The following is a description of a gene set: Reactome Pathway: MECP2 regulates transcription of neuronal ligands Ligands regulated by MECP2 include BDNF, CRH, SST (Somatostatin), and DLL1. part of: Transcriptional Regulation by MECP2 studied in species Homo sapiens, and this is the list of marker genes: SIN3A (SIN3 transcription regulator family member A), CREB1 (NCBI Gene Id 1385), SST, MECP2, DLL1, BDNF, HDAC1, CRH